The following is a description of a gene set: studied in species Homo sapiens Human Gene Set: chr18q11, and this is the list of marker genes: RPS10P27, PPIAP57, SINHCAFP1, GREB1L, ZNF521, AQP4-AS1, SS18, RMC1, ATP7BP1, ENSG00000263611, PA2G4P3, AQP4, RNU6-1289P, RPL21P128, GATA6-AS1, ENSG00000252677, MIR133A1, RAC1P1, RN7SL233P, GREB1L-DT, ENSG00000221139, PCAT18, RNU6ATAC20P, RNA5SP451, WBP2P1, TTC39C-AS1, CABYR, GATA6, PSMA8, MIR320C2, RNU6-435P, RPL23AP77, ENSG00000265751, CIAPIN1P, RBM22P1, CHST9, LINC01543, DHFRP1, HRH4, RNU5A-6P, RNU6-702P, ESCO1, RN7SL745P, TMEM241, TTC39C, ATP6V1E1P2 (ATPase H+ transporting V1 subunit E1 pseudogene 2), ENSG00000263382, LINC02958, ROCK1, KCTD1, ANKRD29, CTAGE1, NPM1P2, SNRPD1, RN7SL97P, NPC1, MIB1, RPS24P18, EXOGP1, RNU6-1032P, IMPACT, MIR1-2, LAMA3, RPS4XP18, LINC01908, MIR4741 (NCBI Gene Id 100616139), RNU6-120P, MIR133A1HG, LINC01915, UBE2CP2, ABHD3, RIOK3, RNU6-1038P, MIR320C1 (microRNA 320c-1), MIR8057, OSBPL1A, EIF4A3P1, SNORA73, UBA52P9, LINC01900 (NCBI Gene Id 102724208), LINC01894, TAF4B, RBBP8, RNA5SP452, CABLES1